Given this list of marker genes Thrb, Smad7, Sox6, Gli3, Pkdcc, Bmpr1b, Prkg2, Loxl2, Hoxa11, Bmp6, Zfp219, Sox9, Mustn1, Runx2 (runt related transcription factor 2), Sox5, Por (cytochrome p450 oxidoreductase), Gdf6, Hoxd11, Smad3, Zbtb16, Gdf5, Rela, Fgf18, here is a description of the gene set: Any process that activates or increases the frequency, rate or extent of chondrocyte differentiation. Mouse Gene Set: GOBP_POSITIVE_REGULATION_OF_CHONDROCYTE_DIFFERENTIATION species: Mus musculus